Given this list of marker genes CBLC, UTP25, TTR (NCBI Gene Id 7276), TRPC5, MED16, COG2, DOK1, VIL1, THAP12, CTSD, ULK1, CDK6, HSD17B4, RPL12, PPP4C, NCAPH2, SULT2B1, TAFAZZIN, FEN1, COPS2, USP18, CCT4, SEC24B, YBX3, GTF2H2, MAD2L1, HOXD9, TRIM25 (NCBI Gene Id 7706), PPP1R7 (NCBI Gene Id 5510), GALNT3, OXA1L, POU6F2, BCAR1 (BCAR1 scaffold protein, Cas family member), CACNA2D1 (calcium voltage-gated channel auxiliary subunit alpha2delta 1), IFNGR1, FYB1, GABRP, PSD, FLOT2, CEMIP2, SMG1, IDH3G, HDLBP, COPB1, SLC20A2, IGFBP3, RAD54L2 (RAD54 like 2), CTSW, MFAP4, ACAT2, HERC1, COL8A2, UGT2B4, BASP1, RCN1, MBD3, PARN, NUP88, SELENOP, ENG, BBOX1, DYNC1LI2, NBL1, here is a description of the gene set: Human Gene Set: RIZKI_TUMOR_INVASIVENESS_2D_DN species: Homo sapiens Genes down-regulated in monolayer (2D) cultures of preinvasive (S3-C) vs invasive (T4-2) breast cancer cells. from publication Rizki A, Weaver VM, Lee SY, Rozenberg GI, Chin K, Myers CA, Bascom JL, Mott JD, Semeiks JR, Grate LR, Mian IS, Borowsky AD, Jensen RA, Idowu MO, Chen F, Chen DJ, Petersen OW, Gray JW, Bissell MJ (PMID 18316601) A crucial step in human breast cancer progression is the acquisition of invasiveness. There is a distinct lack of human cell culture models to study the transition from preinvasive to invasive phenotype as it may occur spontaneously in vivo. To delineate molecular alterations important for this transition, we isolated human breast epithelial cell lines that showed partial loss of tissue polarity in three-dimensional reconstituted basement membrane cultures. These cells remained noninvasive; however, unlike their nonmalignant counterparts, they exhibited a high propensity to acquire invasiveness through basement membrane in culture. The genomic aberrations and gene expression profiles of the cells in this model showed a high degree of similarity to primary breast tumor profiles. The xenograft tumors formed by the cell lines in three different microenvironments in nude mice displayed metaplastic phenotypes, including squamous and basal characteristics, with invasive cells exhibiting features of higher-grade tumors. To find functionally significant changes in transition from preinvasive to invasive phenotype, we performed attribute profile clustering analysis on the list of genes differentially expressed between preinvasive and invasive cells. We found integral membrane proteins, transcription factors, kinases, transport molecules, and chemokines to be highly represented. In addition, expression of matrix metalloproteinases MMP9, MMP13, MMP15, and MMP17 was up-regulated in the invasive cells. Using small interfering RNA-based approaches, we found these MMPs to be required for the invasive phenotype. This model provides a new tool for dissection of mechanisms by which preinvasive breast cells could acquire invasiveness in a metaplastic context.